The following is a description of a gene set: studied in species Homo sapiens part of: Diseases of signal transduction by growth factor receptors and second messengers Reactome Pathway: Signaling by FGFR in disease A number of skeletal and developmental diseases have been shown to arise as a result of mutations in the FGFR1, 2 and genes. These include dwarfism syndromes (achondroplasia, hypochondroplasia and the neonatal lethal disorders thanatophoric dysplasia I and II), as well as craniosynostosis disorders such as Pfeiffer, Apert, Crouzon, Jackson-Weiss and Muenke syndromes. These mutations fall into four general regions of the receptor: a) the immunoglobulin (Ig)-like domain II-III linker region, b) the alternatively spliced second half of the Ig III domain, c) the transmembrane domain and d) the tyrosine kinase domain. With the exception of mutations in class b), which affect only the relevant splice variant, these mutations may be present in either the 'b' or 'c' isoforms. These activating mutations affect FGFR function by altering or expanding the ligand-binding range of the receptors (see for instance Ibrahimi, 2004a), by promoting ligand-independent dimerization (for instance, Galvin,1996; Neilson and Friesel, 1996; d'Avis,1998) or by increasing the activity of the kinase domain (for instance, Webster, 1996; Naski, 1996; Tavormina, 1999; Bellus, 2000). Thus, a number of the point mutations found in FGFR receptors alter their activity without altering their intrinsic kinase activity. Many of the mutations that promote constitutive dimerization do so by creating or removing cysteine residues; the presence of an unpaired cysteine in the receptor is believed to promote dimerization through the formation of intramolecular disulphide bonds. Paralogous mutations at equivalent positions have been identified in more than one FGF receptor, sometimes giving rise to different diseases. For instance, mutation of the highly conserved FGFR2 Ser252-Pro253 dipeptide in the region between the second and third Ig domain is responsible for virtually all cases of Apert Syndrome, while paralogous mutations in FGFR1 (S252R) and FGFR3 (P250R) are associated with Pfeiffer and Crouzon syndromes, respectively. FGFR4 is unique in that mutations of this gene are not known to be associated with any developmental disorders.<br><br>Recently, many of the same activating mutations in the FGFR genes that have been characterized in skeletal and developmental disorders have begun to be identified in a range of cancers. The best established link between a somatic mutation of an FGFR and the development of cancer is in the case of FGFR3, where 50% of bladder cancers have mutations in the FGFR3 coding sequence. Of these mutations, which largely match the activating mutations seen in thanatophoric dysplasias, over half occur at a single residue (S249C). Activating mutations have also been identified in the coding sequences of FGFR1, 2 and 4 (for review, see Wesche, 2011)<br><br>In addition to activating point mutations, the FGFR1, 2 and genes are subject to misregulation in cancer through gene amplification and translocation events, which are thought to lead to overexpression and ligand-independent dimerization. It is important to note, however, that in each of these cases, the amplification or translocation involve large genomic regions encompassing additional genes, and the definitive roles of the FGFR genes in promoting oncogenesis has not been totally established. In the case of FGFR1, translocation events also give rise to FGFR1 fusion proteins that contain the intracellular kinase domain of the receptor fused to a dimerization domain from the partner gene. These fusions, which are expressed in a pre-leukemic myeloproliferative syndrome, dimerize constitutively based on the dimerization domain provided by the fusion partner and are constitutively active.<br><br>, and this is the list of marker genes: FGF22, FGF1, FGF7, GTF2F2, FGF4, POLR2E, PIK3CA, PLCG1, KRAS, FGF8, HRAS (HRas proto-oncogene, GTPase), ZMYM2, PIK3R1, FGF9, CNTRL, NCBP1, STAT3, STAT1, POLR2I, BAG4, FGF18, NRAS, SOS1, POLR2D, FGF6, POLR2A, FGF10 (fibroblast growth factor 10), TRIM24, CPSF6, POLR2C, LRRFIP1, GRB2 (NCBI Gene Id 80715), FGF2 (NCBI Gene Id 2247), FGFR2, BCR, GTF2F1, FGF16, FGF3, FGF5, FGFR4, POLR2K, CUX1, GAB1, FGFR1, STAT5B, FGF23, STAT5A, MYO18A, POLR2F, NCBP2, POLR2G, POLR2H, FGFR3, FGF17, POLR2L, FRS2, POLR2J, GAB2, FGF20, POLR2B, ERLIN2, FGFR1OP2, CEP43